Given this list of marker genes IGF1 (NCBI Gene Id 3479), PINX1, MMP9, SIRT2, SUMO4, SKI, TXN, H1-0, PYHIN1, EDF1, HAND2, EGF, GTF2B, POU4F2, TWIST1, TRIM6, NIBAN2, HMGB1, PLAUR, IFNG, RB1, DAZAP2, FOXC1, NME1, POU4F1, CEBPG, GATA3, NEUROD1, HES1, here is a description of the gene set: Human Gene Set: GOBP_POSITIVE_REGULATION_OF_DNA_BINDING studied in species Homo sapiens Any process that increases the frequency, rate or extent of DNA binding. DNA binding is any process in which a gene product interacts selectively with DNA (deoxyribonucleic acid).